The following is a description of a gene set: Trans-sulfuration pathway Human Gene Set: WP_TRANSSULFURATION_PATHWAY species: Homo sapiens, and this is the list of marker genes: GOT1, MTR, AHCY, CBS, DNMT1, GCLM (glutamate-cysteine ligase modifier subunit), MAT2B, MPST, CTH, CSAD